Given this list of marker genes CEP170, SCO2, MYL6, POMP (NCBI Gene Id 51371), MPHOSPH6 (M-phase phosphoprotein 6), THBS1, AKAP13, ERCC1, ATP6V1B2, RAB7A, ZC3H12A, MT1M (NCBI Gene Id 4499), GPX1, ATP6V0C, ARPC5, ELOC, RNF149, ETF1, ANXA5, RNF19B, NFKB1, LYZ, MAP2K3, ADIPOR1, VCAN, RASSF2, FOS, ASGR1, PIM3, SOD2 (superoxide dismutase 2), SLC43A2 (solute carrier family 43 member 2), IL10 (interleukin 10), HIPK2, TIMP1, DAZAP2, SDS, DUSP6, C1QC, HRH2, PTPN12, GPR84, ADAM9, NECTIN2, DSE, DPYD, IRAK3, RNASE1, CXCL2, NFIL3, RAB5C, MAP2K1, PLIN3 (perilipin 3), TLR1, RNF13, OLR1, CYBB, N4BP1, PLAUR, COTL1, CCL17, MCL1, RAB1A, FGL2, GNB1, CTSZ, CTSL, HLA-DMB, ARHGAP31, LST1, VAMP8, NR4A2, REEP3, SLC39A1, TFDP1, GPX3, REL, C1orf54 (chromosome 1 open reading frame 54, NCBI Gene Id 79630), TFRC, MARCHF2, CMTM3, EDEM1, FCER1G, CTNNA1, PHLDA2, ANPEP, MAFB, COX7B, LRRFIP1, HSBP1, MS4A6A (membrane spanning 4-domains A6A), SCGB1A1, TPM4, CLEC7A, TLNRD1, BASP1, SEMA6B, MT2A, MAT2A, CREM, ALCAM, ETS2, DDX3X, S100A11, GGTA1, FCAR, PPP1CB, EREG (epiregulin), LILRB2, MEF2A, MRC1, SIRPA, RBM47, CPVL, SPHK1 (sphingosine kinase 1), LCP2 (lymphocyte cytosolic protein 2), SLC20A1, GPAT3 (glycerol-3-phosphate acyltransferase 3), SIPA1L1, A2M, GLUL, MAP1LC3B, RAP2B, HLA-DQB2, IL13RA1, SLAMF8, GADD45B, CYRIA, HCLS1, ACSL3, THBD, ATF3, IQSEC1, TBC1D14, AMPD2, FOSB, SLC31A2, IER3, INSIG1, LUCAT1, AKAP12, PNRC1, IFNGR1, CCDC88A, RNF145, HLA-DRB5, ZEB2, SEC14L1, FKBP5, IQGAP1, ZFYVE16, CMTM6, SNCA, TOM1, IL1R1, SH2B3, GRINA, SORL1, RILPL2, BACH1, HLA-DRB6, NOP10, MARCKSL1, PDLIM7, LILRB3, PPT1, SERP1, CD4, GNA12, MAN2B1, SKI, LACTB, RGL1, ABCA1, IFNGR2, ZFAND5, YWHAE, MIDN, KLF4, GLIPR1, MIR4435-2HG, RNASE6, ICAM1, TNFSF8, NEAT1, CHCHD7, DUSP1, ARHGAP18, CH25H, PPIF, JARID2, B3GNT5, EPB41L2, SNX8, PLEKHB2, FCGR2A, TIMM8B, DNAJC15, ST8SIA4, TRMT6, RAB8B, IRF2BP2, SLC2A3, PLEK, RIPK2, IVNS1ABP, CTNNB1 (NCBI Gene Id 1499), TMSB10, SPAG9, SFPQ, STK24, CDKN1A, ZSWIM6, SRGN, DDX3Y, TLR2, ACTN1, MSR1, SLC11A1, MMP19, ATOX1, C1orf162, NIBAN2, ENTPD6, SPI1, MB21D2, JUND, MT1X, IL1B, BIRC2, KCNN4, VDR, QSOX1, GABARAP, ATG3, HIF1A, FCGRT, METRNL, TYMP, GSN, RBMS1 (RNA binding motif single stranded interacting protein 1), AHR, EPB41L3 (NCBI Gene Id 8730), CD83, ATF4, CYTOR (NCBI Gene Id 112597), RAB20, CTSH, FPR3, FGD4, MALT1 (NCBI Gene Id 10892), GNA15, RGS10, ZDHHC20, GNG5, SRC (NCBI Gene Id 6714), LGMN, NICOL1, ITGA5 (integrin subunit alpha 5), SPRED1, SNHG15, MAP3K2, AZI2, SLC16A3, HLA-DPA1, PRELID1, ERGIC1, HCK, C9orf72, FKBP1A, TP53BP2, TNFRSF1A, SLC16A10, CXCL8, POLR2L, GNAQ, TPM3, DYNLT1, FPR2, SERPINB9, HLA-DOA, CTSB, ZYX, CLEC10A, MFSD1, RAB31, MYD88, APLP2, FILIP1L, PRMT9, ZNF706, PICALM, LAT2, SHTN1, ID3, ADGRE2, MAP3K8, NAMPT (NCBI Gene Id 10135), LPCAT2, OTUD1, AGFG1, CHMP1B, GRB2, NINJ1, VEGFA, CD300E, QPCT, EMP1, SKIL (NCBI Gene Id 6498), DUSP4, FTH1, CAB39, BCAT1, MTCH1, SERF2, PLEC, TOP1, SLC25A37, ATP5F1E, TMEM167A, EPAS1, TMBIM6, NFE2L2, RTN4, APOBEC3A, PID1, MKKS, ATP6V0B, CARD19, VASP, TLR4, TPT1, IGSF6, PDXK, ENG, SLC43A3, KPNA4, GK, ANXA2, DPYSL2, PTAFR, PHC2, USP32, HNMT, MARCKS, SLC66A2, ZFP36L1, IL6R, TNFAIP3, SERPINB8, STAB1, KYNU, PEA15, PDE4B, KLHL2, CDCP1, FURIN, IL1RN, PRKAG2-AS1, STX6, CHST11, NLRP3, CCL2, ACTG1, RIN2, RHOU, SYNCRIP, RPS26, AIF1, SKAP2, CLIC1, CD14, PELATON, RHOQ, USP53, RB1, ITGAX, HMGA1, CCR1, SYAP1, NCOR2, HBEGF, MS4A4A (NCBI Gene Id 95933), GNAI2, GAPDH, ENTPD1, SMIM3, ADAM19, IFI27L2, TGFBI, SDC4, PTPRE, ITGAV, ASPH (NCBI Gene Id 56921), AREG, SEM1, SEC61G, MIR22HG (NCBI Gene Id 84981), BAZ1A, PMP22, STARD4, SAMSN1, JDP2, VSIG4, CEBPB, IRS2, MT1A (metallothionein 1A), ATP5MK, TPP1, AP2S1, SHOC2, BCL3, CD86, PKIB, HAVCR2, HLA-DRB1, PIK3R5, TUBA1C, ATP13A3, YWHAZ, MS4A7, GPR183, IFITM3, SLCO2B1, SLC7A5, HLA-DPB1, SH3BP5, COX8A, C15orf48, C3AR1, KTN1, C5AR1, G0S2, SEMA4D, YBX3, CD58, SGK1, CD1C, CDV3, TM9SF3, CD36, SDC2, GSTO1, UPP1, LHFPL2, TBXAS1, EMILIN2, PLAU, SH3PXD2B, HLA-DMA, ENO1, TTYH3, ELL2, CD44, KDM6B (lysine demethylase 6B), ADA2, ATP2B1-AS1, ST14, CCL20, PPARD, CD74, CHMP4B, PDE4A, KCTD12, F13A1, LY96, FPR1, WBP1L, IL1RAP, FCER1A, SUMO3, ENY2, PSAP, S100A10, ACSL1, HLA-DQB1, CD163, TAMALIN, WTAP, FCN1, ELK3, GLIPR2, HLA-DQA2, FTL, LITAF, SLC6A6, IER5, AP1B1, BTF3L4, FGR, OSM, DDX21 (DExD-box helicase 21), SPINT2, RALA, FES, CLTC, CEBPD, MAP3K13, PTPN1, TNFSF13B, TNFRSF12A, MOB3B, HLA-DRA, NCF2, TCN2, RUNX1, DBI, PNP, S100A6, YWHAH, FCGR2B, CSRNP1, JMJD1C, CD93, CXCL3, ZMIZ1, TYROBP, NPC2, PAPSS2, SAP30, SLC1A3, BRI3, CLEC4E, CLEC5A, RGS2, RHOB, IL1R2, EMP3, ARRB2, LGALS1, ANKH, RAC1, DOCK10, LIMS1, PLSCR1, KLF9, UBXN2B, FCGR1A, CSF2RA, BCL2A1, RBPJ, SAT1, ACTB, GABARAPL1, PFKFB3, RGCC, CST3, HLA-DQA1, CXCL16, HNRNPAB, SOAT1, RAP2A, HMOX1, ACTR2, GNA13, AHNAK, GNS, ABL2, CHSY1, TREM1, ANGPTL4, ZNF331, IFI30, FLOT1, SOCS3, CSF1R, ATP1B3, PSTPIP2, MXD1, ETV6, RNF130 (ring finger protein 130), SUSD6, SDC3, QKI, MACROH2A1, PLXDC2, CCRL2, CSTA, here is a description of the gene set: Human Gene Set: TRAVAGLINI_LUNG_EREG_DENDRITIC_CELL studied in species Homo sapiens from publication Travaglini KJ, Nabhan AN, Penland L, Sinha R, Gillich A, Sit RV, Chang S, Conley SD, Mori Y, Seita J, Berry GJ, Shrager JB, Metzger RJ, Kuo CS, Neff N, Weissman IL, Quake SR, Krasnow MA (PMID 33208946)